Given this list of marker genes Tomm7, Atg7, Usp20, Endog, Pim2, Il4, Atp5if1 (NCBI Gene Id 11983), Hmox1, Nod1, Rb1cc1, Irgm2, Bcl2l11, ENSMUSG00000144291, Pik3c2a, Tpcn1, Nprl2, Trim8, Kat5, Atf6, Trim32, Pafah1b2, Sesn2, Trim13, Pip4k2b, Wipi1 (WD repeat domain, phosphoinositide interacting 1), Tlr9, Deptor, Gsk3a, Sptlc2 (NCBI Gene Id 20773), Plekhf1, Atg101, Gba1, Ufl1, Becn1, Tsc2, Wac, Rab3gap1, Nprl3, Sesn1, Nod2, Kdr, Prkaa2, Cers1, Sh3bp4, Plk2, Hif1a, Foxo1, Mul1, Sting1, Smcr8, Elapor1, Rnf31, Htt, Cdc37, Lrrk2, Gpsm1, Atg16l1, Mid2, Clec16a, Plk3 (polo like kinase 3), Atg2a, Hmgb1, Ager, Zc3h12a, Larp1, Ormdl3, Bnip3, Ralb, Vdac1 (voltage-dependent anion channel 1), Stk11, Fbxo7, Trp53inp1, Tmem59, Calcoco2, Snx30, Epm2a, Huwe1, Mefv, Pip4k2c, Stub1, Ticam1, Ifng, Rnf152, Moap1, Csnk2a1, Fyco1, Prkd1, Rab12 (RAB12, member RAS oncogene family), Tlr2, Cdk16 (NCBI Gene Id 18555), Elavl1, Supt5, Hk2, Dele1, Prkaa1, Cdk5rap3, Dcn, Slc35d3, Snx4, Setd2, Sesn3, Smo (smoothened, frizzled class receptor), Sirt1, Svip, Irgm1, Ddit3, Ccny, C9orf72, Gnai3, Scoc, Optn, Flcn, Bag3, Ifnb1, Tfeb, Ikbkg, Foxo3, Slc25a5, Snx7 (sorting nexin 7), Map2k1, Hdac6, Ambra1, Snx18, Sptlc1, Tom1, Tsc1, Rock1, Dapk1, Trim21, Irgq, Ulk1, Bnip3l, Mapk3, Sqstm1, Xbp1, Gsk3b, Wdr24, Hspb8, Pip4k2a, Wdr45, Ubr4, Mtdh, Map3k7 (NCBI Gene Id 93774), Ube2a, Igtp, Rufy4, Tbk1, Adrb2, Atg5, Ddrgk1, Prkn, Slc25a4 (solute carrier family 25 (mitochondrial carrier, adenine nucleotide translocator), member 4), Trim23, Pink1, Vps13d, Eif2ak1, Sh3glb1, Lrsam1 (leucine rich repeat and sterile alpha motif containing 1), Depdc5, Bid, Atg13, Ripk2, Zdhhc19, Rab3gap2, Trim65, here is a description of the gene set: Mouse Gene Set: GOBP_POSITIVE_REGULATION_OF_AUTOPHAGY species: Mus musculus Any process that activates, maintains or increases the rate of autophagy. Autophagy is the process in which cells digest parts of their own cytoplasm.